Given this list of marker genes RBM10, ALKBH5, IWS1, TPR, THOC2, WNK1, SETD2, PRPF31, NEAT1, RIOK2, NSUN2 (NOP2/Sun RNA methyltransferase 2), AKAP8L, HHEX, here is a description of the gene set: Any process in which a ribonucleoprotein complex is transported to, or maintained in, a specific location within a cell. Human Gene Set: GOBP_RIBONUCLEOPROTEIN_COMPLEX_LOCALIZATION studied in species Homo sapiens